The following is a description of a gene set: studied in species Homo sapiens Biosynthesis of EPA-derived SPMs Human Gene Set: REACTOME_BIOSYNTHESIS_OF_EPA_DERIVED_SPMS, and this is the list of marker genes: PTGS2, LTA4H, GPX4, ALOX5, ALOX15, HPGD